Given this list of marker genes LMBRD1, SUOX, EPX, PTGS2, CYP2B6, HBA2, HBG2, CYP4F22, SDHD, ADGB, SLC48A1, PTGES2, CYP4F2, IDO1, CBS, CYP4B1, CYP26A1, CYP2C8, CYP27C1 (NCBI Gene Id 339761), HBQ1, GUCY1A1, CYP17A1, CYP11B1, CYP2J2, FECH, CYP1A2, CYP2A7, STEAP4, CYP26C1, NR1D1, CYP2F1, CYP27B1, STEAP3, NOS3, CYBA, HBM, CYP4X1 (cytochrome P450 family 4 subfamily X member 1), HMOX2, CYP11B2, FLVCR2, THAP4, DGCR8, NOX4, CYP2A6, CYB5D2, CYB5A, CBLIF, TBXAS1, CYGB, CYP7A1, CYP4Z2P, CYP20A1, CYP2E1, CYP4A22, STEAP1, MT-CO1 (mitochondrially encoded cytochrome c oxidase I), CYP4Z1, EIF2AK1, CYP4F3 (cytochrome P450 family 4 subfamily F member 3), CYP11A1, CYP2C9, ABCB6, NOX5, AMBP, GUCY1B1, CYP1B1, CYP3A7, HBD, CYCS, HBE1, TCN1, CYP3A4 (cytochrome P450 family 3 subfamily A member 4), NOX3, NOS2, CYP4F8, CYP4F11, HBZ (hemoglobin subunit zeta), SDHC, MMAB, CYP26B1, CYP46A1, CYP2S1, HEBP2, HMOX1, PTGS1, RSAD1, TCN2, FA2H, CYP3A43, CYP7B1, PGRMC1, NGB, CAT, CYB5R4, CYP2A13 (NCBI Gene Id 95745), PXDNL, HEBP1, STC2, CYP27A1, CYP3A5, KCNH7, CUBN, HBG1, CYP4F12, MMUT, CYP2U1, BACH1, CD320, CYP2C19, CYB5B, CYP24A1, CYP2R1, DUOX1, DUOX2, PXDN (peroxidasin), HBB (NCBI Gene Id 3043), CYP51A1, CYP2W1, IDO2, MPO, CYC1, CYP1A1, PTGIS, CYP19A1, SRC, CYP2G1P, CYP21A2, COX15, CYP39A1, CYP4V2, HBA1, CYP2D6, TDO2, TPO, FLVCR1, CYB561D2, JAK2, CYBB, MTR, MB, GUCY1A2, LPO, NOS1, CYP8B1, MMACHC, ENSG00000274276, HRG (histidine rich glycoprotein), CYP4A11, HCCS, PGRMC2, CYP2C18, here is a description of the gene set: Binding to a tetrapyrrole, a compound containing four pyrrole nuclei variously substituted and linked to each other through carbons at the alpha position. Human Gene Set: GOMF_TETRAPYRROLE_BINDING species: Homo sapiens